Given this list of marker genes Tbx3 (T-box 3), Dicer1, Msx1, Osr2, Atp7a, Shh, Hoxd10, Hotair, Rarg, Mecom, Alx3, Sall3, Gnas, Pitx1, Twist1, Hottip, Lmbr1, Alx4, Med1 (NCBI Gene Id 19014), Aff3, Smarca4, Tfap2b, Fmn1, Wnt7a, Mir23a, Ctnnb1, Osr1, Bmp4, Gdf5, Rarb, Ptch1, Rspo2 (NCBI Gene Id 75417), Hoxd9, Lrp6, Tbx4, Wnt3, Sall1, Fgf4, Fgf8, Chd7, Trp63, Msx2, Large1, Notch1, Zbtb16, Pitx2, Bmpr1a, Gpc3, Rpgrip1l, here is a description of the gene set: The process in which the anatomical structures of the hindlimb are generated and organized. Mouse Gene Set: GOBP_HINDLIMB_MORPHOGENESIS species: Mus musculus